The following is a description of a gene set: studied in species Mus musculus Mouse Gene Set: GOBP_TRNA_TRANSCRIPTION The synthesis of transfer RNA (tRNA) from a DNA template., and this is the list of marker genes: Polr2f (NCBI Gene Id 69833), Polr3a, Polr3d, Polr2e, Polr2l (NCBI Gene Id 66491)